Given this list of marker genes CYSLTR2, CCDC34, ICOS, RAD54L, HSPA4L, BAG1, TTK, ELOF1, MTFR2, C1orf54, ARAP2, ATF6, CALM1, TMPO, FUNDC2, EXO1, SRGN, ARHGAP18, CDC14A, AP2S1, CHSY1, ALMS1, CXCL10, SYPL1, GPR141, FOSL2, NEK2, CLIC1, FAR1 (NCBI Gene Id 84188), DDX28, ZEB2, GBP3, SMC3, CYBB, ITGA2, MXD1, AIF1, SMPDL3B, CHIT1, BST2, PRDM1, ADAM9, TUBB4B, SNX10, NSMAF, SNX18, HIF1A, FAM107B, MELK, RBM3, DUSP4, CHMP2A, STAP1, INSL6, MYO5A, MPO, F10, ORC6, LPIN2, MYO1F, CRELD2, CD80, CXCR6 (C-X-C motif chemokine receptor 6), DTL, LAIR1, DGKH, PTGR1, FKBP5, CLEC5A, VPS37B, SIVA1, MX1, EHBP1L1, TLR4, PERP, MARCKS, CCR1, PTGER4, GCNT1, ELL2, H1-2, CARHSP1, H1-0, NFYB, ASF1B, SNX5, CDC6, ACADL, PLP2, MMP8, GDA, ANXA1, IFI16, GADD45B, PHLDA1, LY86, EZH2, SDF2L1, NPTN, GALNT3, NDUFA1, DNAJB11, ATAD2, GPD2, ITGAM, MFSD10, CASP3, NIBAN1, PTPRJ, KIF14, REEP5, ERN1, RUNX2 (RUNX family transcription factor 2, NCBI Gene Id 860), OCIAD2, PLBD1, SCRN3, MYL4, TBCB, MRPL18, PLA2G7, CD300A, ITGAX, DGAT1, ACOT7, HPRT1, CKAP5, CENPA (NCBI Gene Id 1058), CCZ1, PPM1J, ODC1, HTATIP2, PLK4, GNG10, ALCAM, ARHGAP26, HMGN2, GLRX, SERINC3, FCER1G, CCDC124, CDC27, DUSP16, CDCA2, PRF1, TTC39B, GBP5, CDKN1A, PRKX, SAP30, SAMSN1, ECT2, S100A11, RACGAP1 (Rac GTPase activating protein 1), MPEG1, PTPN12, AP1S2, PGLYRP1, PBK, MRPL27, MCM4 (NCBI Gene Id 780917), ICA1, PHF11, MIS18BP1, MYADM, COBLL1, ATAD5, OGFRL1, APOBEC2, NR1I3, LAMC1, ERCC6L, L1CAM, BAZ1A, SIRPA, CHST11, HOMER1, ITGA1, GMPS, here is a description of the gene set: Human Gene Set: GSE14415_ACT_TCONV_VS_ACT_NATURAL_TREG_DN Genes down-regulated in activated T lymphocytes: T conv versus natural T reg. species: Homo sapiens from publication Haribhai D, Lin W, Edwards B, Ziegelbauer J, Salzman NH, Carlson MR, Li SH, Simpson PM, Chatila TA, Williams CB (PMID 19265124) The gene expression profile of peripheral Foxp3+ natural regulatory T cells isolated from Foxp3/EGFP bicistronic mice was compared to that of in vitro-induced regulatory T cells and to CD4+ conventional (Foxp3-) T cells. The role of the regulatory T cell transcription factor Foxp3 in shaping the transcriptosomes of natural and induced regulatory T cells was analyzed using mice expressing a mutant FOXP3-EGFP fusion protein (Foxp3deltaEGFP). We used gene expression microarrays to examine the transcriptional programs of natural and induced regulatory T cells and the function of Foxp3 in organizing the transcriptosomes of the respective cell type